The following is a description of a gene set: A behavioral process involved in the cycle from wakefulness through an orderly succession of sleep states and stages that occurs on an approximately 24 hour rhythm. species: Mus musculus Mouse Gene Set: GOBP_CIRCADIAN_SLEEP_WAKE_CYCLE_PROCESS, and this is the list of marker genes: Nps, Cort, Ghrl, Uts2, Csf2, Ptgds (NCBI Gene Id 19215), Il6, Adora2a, Chrnb2, Per3, Ptger3, Drd3, Kcna2, Drd2 (NCBI Gene Id 13489), Ghrhr, Parp1, Fxr1, Drd1, Btbd9, Npy2r, Casp1, Ghrh, Uts2r (urotensin 2 receptor), Pmch, Ada, Ptger4, Mtnr1b (NCBI Gene Id 244701), Gabrb3, Pln, Nmu, Nlgn1, Adora1, Adrb1, Alb, Hcrtr2